The following is a description of a gene set: from publication Ben-Porath I, Thomson MW, Carey VJ, Ge R, Bell GW, Regev A, Weinberg RA (PMID 18443585) species: Homo sapiens Human Gene Set: BENPORATH_ES_2 Set 'Set 'ES exp2': genes overexpressed in human embryonic stem cells according to a meta-analysis of 8 profiling studies. Cancer cells possess traits reminiscent of those ascribed to normal stem cells. It is unclear, however, whether these phenotypic similarities reflect the activity of common molecular pathways. Here, we analyze the enrichment patterns of gene sets associated with embryonic stem (ES) cell identity in the expression profiles of various human tumor types. We find that histologically poorly differentiated tumors show preferential overexpression of genes normally enriched in ES cells, combined with preferential repression of Polycomb-regulated genes. Moreover, activation targets of Nanog, Oct4, Sox2 and c-Myc are more frequently overexpressed in poorly differentiated tumors than in well-differentiated tumors. In breast cancers, this ES-like signature is associated with high-grade estrogen receptor (ER)-negative tumors, often of the basal-like subtype, and with poor clinical outcome. The ES signature is also present in poorly differentiated glioblastomas and bladder carcinomas. We identify a subset of ES cell-associated transcription regulators that are highly expressed in poorly differentiated tumors. Our results reveal a previously unknown link between genes associated with ES cell identity and the histopathological traits of tumors and support the possibility that these genes contribute to stem cell-like phenotypes shown by many tumors., and this is the list of marker genes: GOLGA7, MYBL2, LIN28A, AEN, ERCC6L, ZIC3, GPR19, NANOG, ETV4, TXLNG, EPHA1, L1TD1, PWP2, DNMT3A, ORC1, CDC25A, GDF3, RBM4, EPHX3, DTYMK, PRKD3, RRP9, DSCC1, DBNDD1, SLC5A6, WSCD1, NCAPH, HESX1, ORC2, CHEK2, LPAR4, MCM10, POU5F1, CYP26A1, HELLS, PRDM14, GJC1, CLDN6, VRTN, CRIPTO